Given this list of marker genes PDGFC (platelet derived growth factor C), MRAS, IGF1, PDGFD, ARAF, SHC3, PRKCG, MYC, BCL2, EIF4E2, SRC, RPS6, GSK3B, PIK3R2, IL6, MET, BCL2L11, PDPK1, BAX, SHC2 (NCBI Gene Id 400665), GAS6, NF1, MTOR, EIF4EBP1, RRAS2, KDR, JAK2, PDGFA, PDGFRB, PLCG2, RAF1 (NCBI Gene Id 5894), PIK3R3, NRG1, SHC1, AXL, AKT1, VEGFA, STAT3 (NCBI Gene Id 6774), BRAF, TGFA, MAP2K2, PIK3CB, AKT3, PIK3CA, CCND1, SHC4, EIF4E, PLCG1, NRG2, MAPK1, IGF1R, MAPK3, MAP2K1, PIK3R1, EGFR, ERBB2, BCL2L1, HRAS, SOS2, IL6R, NRAS, KRAS, BAD (NCBI Gene Id 572), EGF, RPS6KB2, PDGFB, JAK1, HGF, PDGFRA, GAB1, FGFR3, SOS1, GRB2, FOXO3, RRAS, AKT2, FGFR2, PTEN, ERBB3, RPS6KB1, PRKCB, PIK3CD, FGF2, PRKCA, here is a description of the gene set: EGFR tyrosine kinase inhibitor resistance studied in species Homo sapiens Human Gene Set: WP_EGFR_TYROSINE_KINASE_INHIBITOR_RESISTANCE